Given this list of marker genes App, Itgb2l, Gnai3, Fpr2, Nfe2l2, Egfr, Dhfr, Hvcn1, Mapt, Acp5, Itgb2, Agt, Pon3, Nox1, Cd36, Il18, Cxcl1, Cd177, Gnai2, Gch1, Itgam, Shc1, Akt1, Cyba, F2rl1, Syk, Crp, Fbln5, Elavl1, Tgfb1, Prkcd (protein kinase C, delta), Gstp1, Tyrobp, Sod1, Agtr1a, Clec7a, here is a description of the gene set: Any process that modulates the rate, frequency, or extent of superoxide metabolism, the chemical reactions and pathways involving superoxide, the superoxide anion O2- (superoxide free radical), or any compound containing this species. studied in species Mus musculus Mouse Gene Set: GOBP_REGULATION_OF_SUPEROXIDE_METABOLIC_PROCESS